Given this list of marker genes MMP8, SLC20A2, ALPL, DSPP, VEGFB, CTSK, COL1A1, TGFB1, MEPE, DMP1, SPP1, SMAD1, SLC20A1, ANXA5, COL1A2, ITGB1, VEGFA (NCBI Gene Id 7422), FGF1, here is a description of the gene set: While androgen receptor (AR)-deficient mice developed osteopenia in endochondral bones due to the high bone turnover with increased bone resorption by osteoclasts, little is known about the mechanism of intramembranous bone loss contributed by AR in osteoblasts. Here, we discovered a dramatic decrease in the area of calcification, new bone, and the number of osteocytes in calvaria from AR-deficient mice related to a reduction in mineralization caused, in part, by the diminished activity of AR-deficient osteoblasts. Enforced AR expression in differentiated osteoblasts boosts mineralization while knockdown of AR expression prevents androgen-induced mineralization. We identified the tissue-nonspecific alkaline phosphatase (TNSALP) and several members of small integrin binding ligand N-linked glycoprotein (SIBLING) gene family as androgen target genes required for AR-mediated bone formation. We show that inorganic phosphate (P(i)) levels and TNSALP activity increased in response to androgen/AR and P(i) signals increase the expression and translocation of AR. The ectopic expression of TNSALP or P(i) partially rescued the bone loss due to AR deficiency. Thus, androgen/AR signaling plays an essential role in bone formation by coordinating the expression of genes associated with phosphate regulation. Genes down-regulated in osteoblasts from wild type male mice compared to those with AR knockout. Human Gene Set: KANG_AR_TARGETS_DN from publication Kang HY, Shyr CR, Huang CK, Tsai MY, Orimo H, Lin PC, Chang C, Huang KE (PMID 18838539) species: Mus musculus